Given this list of marker genes Ccl7, Hrg, Cxcl17, Robo3, Cx3cr1, Fgf18, Creb3, Dscam, BC037156, Ccl2, Ccr2, Coro1b, Tnfsf18, Smoc2, Tnfaip6 (NCBI Gene Id 21930), Prkd1, Swap70, Gstp1, Ccl21e, Mdk, Wnk1, Mcu, Pdgfra, Dapk2, F7, Fgf16, Sema3f, Gstp2, Edn3, Adam10, Nova2, Il23a, Rin3, Ptgr1, Rac1, Fpr-rs3, Ccl19, Ager (NCBI Gene Id 11596), Oxsr1, Hspb1, Fgf2, Pdgfd, Il12a, Stap1, Robo1, Perp, Mstn, Slit1, Ppbp, F2rl1, Usp14, Hc, Prkd2, Il34 (interleukin 34), Rac2, Klrk1, Cxcl13, Bst1, Scg2, Bmpr2, App, Ccl19-ps3, Pgf, Sucnr1, C5ar2, Edn2, Ccr1, Smad3, Csf1r, Slit2 (NCBI Gene Id 338531), Grem1, Vegfc, Ccr6, Thbs1, C5ar1, Angpt2, Akirin1, Lpar1, Ripor2, Padi2, Ccl1, Lbp, Mmp28 (NCBI Gene Id 237892), Ccr1l1, Stk39, Ntf3, Ccl21a, Csf1, Mapk3, Cxcl12, Plxna3 (plexin A3), Ccl21f, Cxcl10, Fgf4, Fpr2, Wasl, Il4, Gpr183, Tubb2b, Defb25, Kdr, Stx4a, Sema5a, Cxcr2 (NCBI Gene Id 12765), Mtus1, Tpbg, Lgals9, Trem1, Wnt3, Mapk1, Nbl1, Cyrib, Cttn, Tgfb1, Snai2, Tirap, Pdgfrb, Fgf1, Robo2, Fezf2, Artn, Mst1, Ccl5, P2rx4, Il16, Plxna4, Vegfb, Wnt5a, Fgf10, Gpsm3, Sell, Fpr-rs6, Cxcr4, St6gal1, Ccr4, Gas6, Trem2, Ccl26 (C-C motif chemokine ligand 26), Ptpn2, Akt2, Slamf1, Serpine1, Efnb2 (ephrin B2), Nrp1, Jam3, Ptk2b, Adam17, Sema3a (sema domain, immunoglobulin domain (Ig), short basic domain, secreted, (semaphorin) 3A), Shh, Tmem102, Agrn, Camk1d, Ccl21d, Ccl19-ps1, Slamf8, Mif, Calr, Ccl19-ps6, Ptn, Adgra2, Mpp1, Spi1, Aif1, Ntrk3 (NCBI Gene Id 414121), Nod2, Ryk, Fpr-rs4, Fn1, C1qbp, Pou4f2, Ythdf1, Rarres2, Atoh7, Il1b, S100a14, Ccn3, Vegfa, Ano6, Ccl12 (NCBI Gene Id 20293), Ccl21b, Ninj1, Pdgfb, Gpr18, Nedd9, Megf8, Stx3, Cxcl14, Cxcr3, Ccr7, Ptk2, Dusp3, Lgmn, Met, Xcl1, Ppm1f, Edn1, Dusp1, Fpr-rs7, Ccl19-ps5, Cmklr1, Dysf, Tbr1, Wnt3a, Cx3cl1, Itga2, Hmgb1, Cdh13, Pla2g7, Ccl19-ps4, Tmsb4x, Trpv4, Cyp19a1, S1pr1, Lyn, Ptprj, Casr (calcium-sensing receptor), Tiam1, Prkca, Tnfsf14, Nckap1l, Vegfd, Fgfr1, Dnm1l, Mycbp2, P2ry12, Zfp580, Thbs4, Kif21a, Mospd2, Slc8b1, Notch1, Cd74 (CD74 antigen (invariant polypeptide of major histocompatibility complex, class II antigen-associated)), Dpp4, Ccl3 (NCBI Gene Id 20302), Hdac6, C3ar1, Ednra, here is a description of the gene set: Mouse Gene Set: GOBP_REGULATION_OF_CHEMOTAXIS Any process that modulates the frequency, rate or extent of the directed movement of a motile cell or organism in response to a specific chemical concentration gradient. studied in species Mus musculus